The following is a description of a gene set: from publication Chen Y, Wang X (PMID 31504780) studied in species Mus musculus Genes predicted to be targets of miRBase v22 microRNA mmu_miR_7664_5p in miRDB v6.0 with MirTarget v4 prediction scores > 80 (high confidence targets). Mouse Gene Set: MIR_7664_5P, and this is the list of marker genes: Armcx3, Epha3, Gm20917, Dnaaf9, Slc37a3 (NCBI Gene Id 72144), Jmy, Bclaf1, Ndfip2, Pou2af3, Osbpl3, Cdkn2aip, Tlk1, Pbx1, Nkx2-2, Rubcn, Larp4b, Btf3l4, Cyfip1, Greb1l, Cnot6, Hnf1b, Prrg1, Pnpt1, Bmt2, Npy1r, Mier3, N4bp2l2, Tsr2 (TSR2 20S rRNA accumulation), Pkd2, Klf3, Suz12, Gpr82, Tmtc3, Ankrd17, Bahcc1, Klf4, Utp23, Fbxl3, Nwd2, Fkbp3, Mecom, Trdn, Qsox2, Casp6, Esr1, Sv2b, Cited2, Rmdn1, Pdhx, Gm12886, Tcf12, Ankib1, Hmgcr, Lrrtm1, Rufy2, Rnf220, Rap1b, Stag1, Dstn (destrin), Rcor3, Crim1, Hnrnpf, Usp54, Ahr, Syne2, Cyp26b1, Tmem65, Adam10, Zmpste24, Zbtb44, Ppp4r2, Prickle2, Snx18, Cand1, Pip5k1b, Fzd6, Ubl3, Pid1, Ppfia1, Rtn4rl1, Tmem164, Atp6v1a, Polk, Hk1, Immp1l, Vps4b, Pou3f2, Creb3l4, Caps2, Cnot1, Slbp, Fbxo28, Pcdhb15, Prss59, Zmym2, Ltb, Fus, Fbn1, Ccne2, Pdpk1, Rftn2, Tvp23b, Ell2, Tmem41b, Ankdd1b, Slc30a5, Olfm3, Rab6b, Igdcc4, Lhfpl2, Acsl5, Add3, Zfp655, Dmrt3, Selenoi, Agrn, Smad2, Eloa, Taf4, Itga2, Lysmd2, Ube2q2, Gak, Bex4, Pgr, Atrn, Zbtb10, Zfp131